Given this list of marker genes KMT2D, ASH2L (NCBI Gene Id 9070), WDR5, RBBP5, DPY30, here is a description of the gene set: part of: Loss of Function of KMT2D in Kabuki Syndrome species: Homo sapiens Reactome Pathway: Loss of Function of KMT2D in MLL4 Complex Formation in Kabuki Syndrome <p>The entire C-terminal region of histone-lysine-N-methyltransferase KMT2D (residues 4507-5537), which includes the ZF, PHD7, FYRN, FYRC, WIN and SET domains, is involved in binding to the WRAD complex. Missense mutations in the C-terminal region of KMT2D, identified in Kabuki syndrome patients, affect its binding to the WRAD complex, consisting of WDR5, RBBP5, ASH2L and DPY30. While the impact of KMT2D truncating mutations on the WRAD complex binding has not been tested, they were shown to frequently result in KMT2D mRNA degradation through nonsense-mediated mRNA decay and contribute to haploinsufficiency.</p>